The following is a description of a gene set: Secundum atrial septal defect A kind of atrial septum defect arising from an enlarged foramen ovale, inadequate growth of the septum secundum, or excessive absorption of the septum primum. Human Gene Set: HP_SECUNDUM_ATRIAL_SEPTAL_DEFECT species: Homo sapiens, and this is the list of marker genes: RRAGC, ADK, HEATR3, SH3PXD2B, GDF1, PRRX1, FILIP1, STK4, BUB1, MYH6, DOHH, SHMT2, KDM6A, POLR3A, TRIP4, NAA10, KAT6A, MEIS2, METTL5, FLII, TBX5, NKX2-5, IDH1 (NCBI Gene Id 3417), ACTC1, NR2F2, COG7, CHD7, PTF1A, IFT56, PRDM13, ATP2B1, EIF4A2, NF1, H4C3, G6PC3, GATA6, USP18, CEP295, H4C9, ATP9A, KDM5B, GET3, ATIC, ZNF668, PGAP1, RPL11, KMT2D